Given this list of marker genes Tap1, Pim1, Irf8, Tor1aip1, Iigp1, Gbp2, Tgtp2, Gbp5, Ly6a, Irf9, Irf1, Parp14, Gbp7, Ifit1, Xaf1, Ube2l6, Mxd1, Dtx3l, Socs1, Trim30a, Irf7, Mvp, Zbp1, Igtp, Ifitm3, Ifi207, Stat2, Clic4, Isg15, Mndal, Csf2rb2, Slfn5, Parp9, Stat1 (signal transducer and activator of transcription 1), Ifi47, Psme2, here is a description of the gene set: Cytokines mediate cell-cell communication in the immune system and represent important therapeutic targets. A myriad of studies have highlighted their central role in immune function, yet we lack a global view of the cellular responses of each immune cell type to each cytokine. To address this gap, the authors created the Immune Dictionary, a compendium of single-cell transcriptomic profiles of more than 17 immune cell types in response to each of 86 cytokines (>1,400 cytokine-cell type combinations) in mouse lymph nodes in vivo. A cytokine-centric view of the dictionary revealed that most cytokines induce highly cell-type-specific responses. For example, the inflammatory cytokine interleukin-1β induces distinct gene programmes in almost every cell type. A cell-type-centric view of the dictionary identified more than 66 cytokine-driven cellular polarization states across immune cell types, including previously uncharacterized states such as an interleukin-18-induced polyfunctional natural killer cell state. Genes positively differentially expressed in cell type: Mast cell upon treatment with cytokine: IL-15 in mouse lymph nodes in vivo. from publication Cui A, Huang T, Li S, Ma A, Pérez JL, Sander C, Keskin DB, Wu CJ, Fraenkel E, Hacohen N (PMID 38057668) species: Mus musculus Mouse Gene Set: CUI_MAST_CELL_IL15_RESPONSE_UP